Given this list of marker genes Ccnh, Rpa1, Cul4b, Polr2l, Polr2b, Pold4, Ercc2, Uvssa, Polr2c, Tcea1, Ubb, Pold2, Pole (polymerase (DNA directed), epsilon), Xab2 (XPA binding protein 2), Polr2i, Polr2e, Polk, Rfc3, Cul4a, Pold1, Ercc6, Ercc3, Pole2, Lig1, Zfp830, Polr2a, Ddb1, Xrcc1, Pcna, Prpf19, Rfc1, Rps27a, Gtf2h2, Polr2f, Gtf2h4, Polr2k, here is a description of the gene set: species: Mus musculus Reactome Pathway: Gap-filling DNA repair synthesis and ligation in TC-NER This event has been computationally inferred from an event that has been demonstrated in another species.<p>The inference is based on the homology mapping from PANTHER. Briefly, reactions for which all involved PhysicalEntities (in input, output and catalyst) have a mapped orthologue/paralogue (for complexes at least 75% of components must have a mapping) are inferred to the other species. electronically inferred by orthology from the curated human pathway part of: Transcription-Coupled Nucleotide Excision Repair (TC-NER)